The following is a description of a gene set: species: Homo sapiens Human Gene Set: HALLMARK_MYC_TARGETS_V2 A subgroup of genes regulated by MYC - version 2 (v2). from publication Liberzon A, Birger C, Thorvaldsdóttir H, Ghandi M, Mesirov JP, Tamayo P (PMID 26771021), and this is the list of marker genes: GRWD1, PUS1, SORD, CDK4, NIP7, TFB2M, PLK1, LAS1L, SLC19A1, RABEPK, RRP12, MPHOSPH10, NPM1, RCL1, FARSA, MYBBP1A (MYB binding protein 1a), NOC4L, RRP9, PPAN, CBX3, MAP3K6, SRM, TCOF1, NDUFAF4, TBRG4, IMP4, GNL3, PHB1, PRMT3, UNG, HSPE1, DUSP2 (dual specificity phosphatase 2), PES1, PLK4, PA2G4, NOP2, WDR43, TMEM97, DDX18, HSPD1, WDR74, EXOSC5, AIMP2, HK2, MRTO4 (MRT4 homolog, ribosome maturation factor), MYC, UTP20, DCTPP1, NOP16, IPO4, SUPV3L1 (Suv3 like RNA helicase), SLC29A2, NOLC1, MCM4, BYSL, MCM5, PPRC1, NOP56 (NOP56 ribonucleoprotein)